The following is a description of a gene set: Mouse Gene Set: GOBP_GOLGI_TO_PLASMA_MEMBRANE_TRANSPORT studied in species Mus musculus The directed movement of substances from the Golgi to the plasma membrane in transport vesicles that move from the trans-Golgi network to the plasma membrane, where they fuse and release their contents by exocytosis., and this is the list of marker genes: Amn, Exoc2, Exoc8, Vamp3, Vamp2, Arfrp1, Sys1, Krt18, Exoc1, Exoc6b, Arfgef2, Vamp4, Blzf1, Lypla1, Rab26, Llgl2, Rab10, Rabep1, Rab31, Optn, Golph3l, Llgl1, Golph3, Ccdc22, Rack1, Sptbn1, Vamp5, Ank3, Exoc4, Rab13, Golga4, Kif13a, Bbs2, Ccdc93, Steap2, Acsl3, Pkdcc, Golga7, Chic2, Rab34, Prepl, Csk, Rab11fip3, Commd1, Stxbp5, Atp2c1, Exoc5, Lyplal1, Macf1, Exoc6, Nsf, Sec16a, Dnm2, Gga2, Phaf1, Stxbp5l, Bbs1, Vps35l, Arl3, Cnst, Cln3, Gga3, Gga1